The following is a description of a gene set: from publication Gil MP, Ploquin MJ, Watford WT, Lee SH, Kim K, Wang X, Kanno Y, O'Shea JJ, Biron CA (PMID 22968462) Genes up-regulated in CD8 T cells: untreated versus interferon alpha. Type 1 IFNs can conditionally activate all of the signal transducers and activators of transcription molecules (STATs), including STAT4. The best-characterized signaling pathways use STAT1, however, and type 1 IFN inhibition of cell proliferation is STAT1 dependent. We report that type 1 IFNs can basally stimulate STAT1- and STAT4- dependent effects in CD8 T cells, but that CD8 T cells responding to infections of mice with lymphocytic choriomenigitis virus have elevated STAT4 and lower STAT1 expression with significant consequences for modifying the effects of type 1 IFN exposure. The phenotype was associated with preferential type 1 IFN activation of STAT4 as compared to STAT1. Stimulation through the TCR induced elevated STAT4 expression, and STAT4 was required for peak expansion of antigen-specific CD8 T cells, low STAT1 levels, and resistance to type 1 IFN-mediated inhibition of proliferation. Thus, a mechanism is discovered for regulating the consequences of type 1 IFN exposure in CD8 T cells, with STAT4 acting as a key molecule in driving optimal antigen-specific responses and overcoming STAT1-dependent inhibition of proliferation. Human Gene Set: GSE40666_UNTREATED_VS_IFNA_STIM_CD8_TCELL_90MIN_UP species: Homo sapiens, and this is the list of marker genes: TRPM6, TNFAIP8, UNC5A, NUDCD1, DUXAP10, MOS, PPP1R27, C11orf97, UBE2Z, GPR78, DOT1L, SUGT1P1 (SUGT1 pseudogene 1), POM121L12, RPS6KA6, MFAP2, EXTL1, RHAG, LYST, ANO8, PYCR1, PGGHG, ENAH, KLK4, KCNC2, PRRT2, SFRP1, STUB1-DT, ANO1, AMBP, CD274, TEX22, SLC7A5, VAV2, MAST4, SYT9, LINC02579, PICART1, CNTF, EP400P1, RCOR2, ADCY5, LINGO3, UST, MIR34BHG, FSCN2, TSSK2, PADI3, EEF1A2, DUSP5, LINC00161, GALR3, PRNT, ALPI, MPP2, RTP4, MSANTD3, DGCR6L, SLC2A3, LYPD4, FZD9, GATA6, CHODL, OR6W1P, CLIP1, WFIKKN1, LINC01622, KITLG, ADAMTS10, GUCY1B2, CCDC157, PROX1-AS1, OXCT2, MYCN, UBE2NL, KIR3DX1, STRN3, NECAB2, KRTAP8-1, OR4C1P, CYP2B6, COL4A6, PCOLCE, WNK2, HELZ2 (NCBI Gene Id 85441), NODAL, LRRC27, TNMD, MATN1, GALR2 (NCBI Gene Id 8811), TCL1A, CD109, GPD2, HSH2D, FFAR1, PPP2R3B, CPEB3, ENSG00000230725, C14orf180, TSPEAR-AS1, KRT3, RP1L1, GVQW3, LDHA, PALS2, NRL, CCDC103, LINGO1, RNF151, ARF6, NCDN, KRT19, LRP12, CCDC70, CSPG4, IFIT3, GOLGA4, C20orf181, FRMD1, ARAP2, PLAT, DUOXA1, MVK, CALCB, MARCKSL1, PTGDR2, EPSTI1, GUCY2D, PIM3, TMEM88, BCL6B, KMT2D, TMEM61, LINC02028, IFI44, INSIG1, FAM170A, PARP9, MROH2B, CCDC158, TMEM179, LINC01019, LIPG, RBM46, DCHS2, LINC02907, LCE1E, KRT75, TMEM221, EDARADD, DDX51, FOXP2, CATSPERG, POU4F2, CALHM5, CERS4, ANKRD26P3, RNASE11, SH2D1A, MIR124-1HG, ZNF536, H1-1, NKPD1, ACP4, OR10C1, SERPINB9, MLNR, MX1, MMP16, OBSL1, NEO1, TMIGD2, MUC4, HOXA10, DDC, POU5F1B, UBE2E1, PPP4R2, MPP3, DEFA4, UBE2QL1, ZNF707, TMEM171, EMX1, SLC22A23, SLC39A14, TENT4B